Given this list of marker genes Ucn2, Smad4, Foxd1, Tbx3, Oprk1, Foxl2, Oprm1, Cga, Tacr2, Tmf1, Crh, Crhr2, Kiss1, Lep, here is a description of the gene set: studied in species Mus musculus Mouse Gene Set: GOBP_LUTEINIZING_HORMONE_SECRETION The regulated release of luteinizing hormone, a gonadotropic glycoprotein hormone secreted by the anterior pituitary.